The following is a description of a gene set: Parkinson's disease studied in species Mus musculus Mouse Gene Set: WP_PARKINSONS_DISEASE, and this is the list of marker genes: Ccne2, Mapk13, Mapk11, Mir26b, Septin5, Lrrk2, Mir485, Ube2g2, Mirlet7g, Mir30e, Cycs, Ccne1, Mir19a, Mir873a, Htra2, Mir375 (NCBI Gene Id 723900), Uba1, Ube2j2 (NCBI Gene Id 73831), Ddc, Prkn, Casp7, Ube2l6, Park7, Slc6a3, Mir873b, Eprs1, Mir30f, Casp3, Gpr37, Mapk14, Mir136, Uba7, Apaf1, Snca, Mir370, Pink1, Mir1224, Casp9, Mir409, Atxn2, Ube2l3, Mir503, Mir338, Mir10a, Ubb, Mir16-2, Mir212, Casp6, Sncaip, Uchl1, Mir127, Mir34b, Ube2g1, Casp2, Syt11, Mapk12, Th, Mir433, Ube2j1